The following is a description of a gene set: Mouse Gene Set: chr5D species: Mus musculus, and this is the list of marker genes: Adgrl3, Gm25756, Gm2199, Gm26335 (NCBI Gene Id 115490220), Gm18452, Gm22974, Mthfr-ps1, Gm23429